The following is a description of a gene set: Human Gene Set: HP_MACRODONTIA_OF_PERMANENT_MAXILLARY_CENTRAL_INCISOR species: Homo sapiens Macrodontia of permanent maxillary central incisor Increased size of the maxillary central secondary incisor tooth., and this is the list of marker genes: ATP6V1B2, TBC1D24, FARS2, BRF1, GJA1, COL11A1, GRIA3 (glutamate ionotropic receptor AMPA type subunit 3), PACS2, BRD4, VPS13B, CACNA1I, KCNMA1, CTCF